Given this list of marker genes Deptor, Zfp971, Fga, Larp6, Cd3d, Lrrtm3, Atp2a2, Meox2, Greb1, Rho, Bloc1s5, Zmat4, Gja8, Slco1a1 (NCBI Gene Id 28248), Cd300e, Trmt10b, Mab21l3, Ripor2, Litaf, Cst5, Ell, Rgs9bp, Kctd9, Vmn2r89, Taf1, Man2a2, Bahd1, Zfp429, Trpm3 (transient receptor potential cation channel, subfamily M, member 3), Dennd5a, Ammecr1, Aldh3b2, Kalrn, Entpd7 (NCBI Gene Id 93685), Sla2, Coa7, Rph3a, Fam168a, Rhd, Clcn3, Scaf8, Kcna7, Zmat2, Sorbs1, Amer3, Trim3, Kcnj3, Phip, Bicd1, Mcc, Slc16a12, Epcam, Ints3, Gab2, Serpinc1, Alkal2, Frmd7, R3hcc1l, Zranb2, Aldh3b3, Ntrk2, Pappa2 (pappalysin 2), Gls2, Dnajb7, Mpdz, Ccr9, Foxi1, Ebf3, Meis3, Atcay, Gm14295, Slc17a3, Ceacam18, Rsl1, Crb1, Rhoh, Elac1, Zfp128, Man1a2, Sgsh, Slc1a1, Prrg3, Prkar2a, Agbl3, Ptchd4, Tshz2, Ctdspl2, Pp2d1, Snrk, Slc30a4, Strn, Xirp2, Izumo1r, Zfand4, Mat2a, B3gat1, Lmx1a, Zdhhc9, Thumpd2, Cpsf7, Zfp438, Gdi2, BC004004, Krr1, Diras1, H60c, Il1r1, Ncl, Klhl29, Sem1, Ptk6, Ndnf, Xiap, Tmem178b, Lhfpl4, Efna3, Zfp1009, here is a description of the gene set: from publication Chen Y, Wang X (PMID 31504780) Genes predicted to be targets of miRBase v22 microRNA mmu_miR_12179_5p in miRDB v6.0 with MirTarget v4 prediction scores > 80 (high confidence targets). Mouse Gene Set: MIR_12179_5P species: Mus musculus